Given this list of marker genes Mir345, Mir182, Trem2, Th, Inava, Cited1, Reg3g, Il12b, Defa42, Fbxo3, Src, Letmd1, Itgav, Cdc73, Ptgfr, Mir29a, Defa35, Mif, Mir194-1, Mir486, Il18 (NCBI Gene Id 16173), Ticam2, Defa34, Cnr1, Selenos, Tnf, Hmgb1, Gstcd, Mir24-1, Mpo, Nfkbib, Trim41, Bpi, Noct, Tnip1, Ptafr, Cd36, Ctr9, Nr1h4, Ifnar1, Map2k7, Gja1, Pdcd1lg2, Mir10a, Il1f10, Casp7, Mir184, Mirlet7a-2, Havcr2, Dab2ip, Fmo1, Casp1, Spi1, Defa5, Defa21, Chmp5, Mapk14, Defa38, Fgf10, Mir350, Mir223 (NCBI Gene Id 723814), Mir30c-1, Mir181b-2, Cfh, Ptger3, Nfkbiz, Tcf3, Trim5, Ptger4, Pcsk1, Mapk8, Gpr31b, Selenof, Plscr3, Sash1, Ang4, Mir194-2, F2r, Adipor2, Pycard, Kmo, Pf4, Ido1, Abcb1a, Cactin (NCBI Gene Id 70312), Otud5, Bdkrb1 (bradykinin receptor, beta 1), Tab2, Il12a, Defa41, Mir23b (NCBI Gene Id 387217), Foxp3, Irf3, Mir29b-2, Esr2, Ncl, Sgms1, Hmgb2, Mir7-1, Wnt5a, Il36g, Mir30c-2, Cnr2, Acp5, H2-M3, Il6, Mir24-2, Bcr, Trim12a, Defa25, Lcn10, Irak3, Ncf2, Ghsr, Arid5a, Trim30a, Stat1, Tirap, Mir139, Mir16-2, Ifng, Mir467d, Ccl28, Cd24a, Ren1, Mir199a-2 (NCBI Gene Id 723821), Extl3 (exostosin-like glycosyltransferase 3), Cd6, Fer, Prpf8, Mir202, Sbno2, Umod, Ikbip, Mapkapk3, Tlr2, Alpl, Ptger1 (prostaglandin E receptor 1 (subtype EP1)), Cd14, P2rx7, Tnfsf4, Ogt, Stap1, Gbp10, Gch1, Card9, Sod2, Plscr2, Mir672, Defa24, Trim30c, Plcg2, Ttc39aos1, Trim30b, Jak2, Elane, Irf5, Rps6kb1, Igtp, Scgb1a1, Mir425, Gfer, Nlrp3, Paf1, Efnb2, Il1b, Trpv4, Xbp1, Hnrnpa0, Trib1, C5ar1, Defa2, Cebpe, Edn1, Abca1, Ephb2, Mir181c (NCBI Gene Id 723819), Upf1, Defa17, Col6a1, Gbp3, Defa30, Ptpn6, Mir494, Nlrc3, Nr1h3, Tnfrsf1b, Cxcl15, Ly96 (NCBI Gene Id 17087), Nr1d1, Ccr7, Peli1, Thbd, Bcl10, Akap8, Penk, Snca, Plscr1, Bmp6, Cyp1a1, Epsti1, Csf3, Nfkb2, Lias, Mir146, Palm3, Cd68, Adam9, Mir107, Ssc5d, Klrk1, Blvra, Cnp, Adamts13, Defa20, Nr2c2, Mir199a-1, Nod2, Slc11a1, Cdk19, Mgst1, Mir15a, Defa31, Atp4b, Smad6, Mir484, Irak2, Irak1, Mir181a-2, Myd88, Mir147, Nfkb1, Nos1, Irf8, Naglu, Lyn, Mir217, Spon2, Cxcl10, Mir381, Cxcl9, Mapk1, Fosl2, Defa39, Tifab, Cd55, Cyp27b1, Ccl27a, Mir409, Eif2ak2, Zc3h12a, Tnfrsf11a, Trim55, Il10, Srr, Cx3cr1, Alad, Pde2a, Cd96, Igkj1, Slpi, Pabpn1 (poly(A) binding protein, nuclear 1), Selenow, Ppard, Mmp8, Pdcd4, Cxcl5, Ugt1a1, Akt1, Capn2, Ctsg, Btk, Nr1i2, Malt1, Traf6, Mir342, Tbxa2r, Rps6ka3, Lbp, Rela, Mir29b-1, Akap12, Trim30d, Dusp10, Mir500, Mef2c, Defa37, Akirin2, Defb21, Mir181a-1, Cd55b, Cx3cl1, Ly86, Vim, Gpx4 (NCBI Gene Id 625249), Mir26b, Il10ra, Mir155, Cd84, Cd274, Il36rn (interleukin 36 receptor antagonist), Cyrib, Mir146b, Maob, Litaf, Mir30b, Hmgcs2, Gbp2b, Defa23, Plscr4, Ptgir, Gjb2, Cmpk2, Wdr83, Epo, Abl1, Ankrd1, Prkca, Mir142, Gbp6, Lta, Mir511, S100a14, Trim6, Camp, Ripk2, Cxcl16, Cd300lb, Prdx2, Axl, Notch1, Foxp1, Mir7-2, Ahr, Xiap, Trim12c, Fcgr4, Mir27a, Tnip2, Nfkbia, Casp9, Cd86, Gjb6, Tspo, Cxcl13, Nqo1, Slc7a5, Adm, Mir98, Ppm1e, Cxcl2, Mir193a, Cebpb, Tfap2a, Irgm1, Mir501, Tut4, Il36b, Bin1, Ptpn22, Ptger2, Mir598, Scarb1, Il12rb2, Ace, Ccl2, Irgm2, B2m, Mir224, Adam17, C2, Defa28, Fcgr2b, Nos2, Stat5b, Tnfaip3, Hadhb, Fzd5, Lilrb4a, Scimp, Irak4, Cr2, Mir26a-1, Lgals9, Cd180, Sirpa, Shpk, Defa26, Il36a, Cdk4, Il1a, Ldoc1, Gbp5, Plaa, AY761185, Mir26a-2 (microRNA 26a-2), Mir383, Il23r, Raet1d, Mir433, Mir200c, Ptpn11, Aicda, Ppbp, Rara, Mir431, Casp3, Gbp2, Wfdc21, Abr, Tjp1, Defa40, Pck1, Rhoa, Defb25, Nuggc, Kcnj8, Cps1, Star, Tnip3, Pde4d, Tlr4, Mrc1, S100a8, Tap2, Ptgs2, Mapk3, Casp4, Gpx1, Gfi1, Fos, Defa3, Ass1, Pde4b, Hpgd, Nos3, Hsf1, Mir7b, Slco1b2, Ltf, Mtdh, Zfp36 (NCBI Gene Id 22695), Tlr9, Cd80, Tlr6 (toll-like receptor 6), Nkx2-1, Prkce, Mgst2, Mir210, Ccr5, Ednrb, Mirlet7g, Fasl, Rac1, Adh5, Mir150, Slc12a2, Havcr1, Acod1, Mir205, Ggt1, Mir323, Prdx3, Erbin, Gstp1, Git1, Gata1, Defa22, Nr4a1, Defa29, Mir140, Map2k3, Nfkbil1, E2f1, Cldn1, Mir293, Rpl13a, Tlr1, Ticam1, Serpine1, Ednra, Mir30d (NCBI Gene Id 387228), Mir125a, Mapkapk2, here is a description of the gene set: Mouse Gene Set: GOBP_RESPONSE_TO_MOLECULE_OF_BACTERIAL_ORIGIN studied in species Mus musculus Any process that results in a change in state or activity of an organism (in terms of movement, secretion, enzyme production, gene expression, etc.) as a result of a stimulus by molecules of bacterial origin such as peptides derived from bacterial flagellin.